Given this list of marker genes FAAP20, TMEM230, GOLGA8H, FAM210B, IPO8, BCDIN3D, TIMMDC1, ZDHHC7, SDHD (NCBI Gene Id 91899), UBL7, NUDT16L1, TRMT5, RAP1A, FES, PRPF6, PGAM1, DPAGT1, CALHM2, TRIM14, ATPAF1, CDK2AP1, DNAJC10, RAC1 (Rac family small GTPase 1), ZWINT, ZNF250 (zinc finger protein 250), TMEM175, ARHGDIB, CAST, ABL1, SORD, TP53TG1, ZFTRAF1, GHDC, ZCCHC13, PLAAT3, MYO1F, GIT2, ADISSP, LIX1L, ZNF362, EIF4A3, FKBP1A, CDKAL1, ITFG1, ACSM3, TCFL5, BTD, SAP30 (NCBI Gene Id 8819), MR1, TMPRSS5, ERCC5, SIPA1, MRPS26 (NCBI Gene Id 81568), ZFYVE19, PCYOX1, DDRGK1, TUBA1C, VAMP8, PYCARD, STMN1, ACBD6, RIDA, STOML1, MIPEP, EHHADH, SNTB1, AHCY, NSMCE4A, RAP1GAP2, KATNB1 (katanin regulatory subunit B1), ATXN10, NAPSB, ARHGAP15, DOCK8, SMARCA2, LDHA, DCXR, SP110, NHERF1, RASGRP4, STK24, RNF214, NUDT6, BRDT, MYCL, ZNF124, CHN2, CTDSP1, ANAPC5, PSME3IP1, TMEM97, DPYD, TCF19, STARD13, DARS2, FBXW4, GDPD5, OAS2, TTC9C, ZNF215, OXNAD1, GIMAP8, AUH, TCIM, GSTK1, EIF3D, VPS35, NUP88, IFI16, MRPS34, MAF, ACLY, SDC3, GPS1, DPH5, WASHC5, CCR1, PARL, CHST12, DDX51, AP3S1, ZNF467, LAPTM5, UVRAG, POLR1E, H2AZ1, HVCN1, OSBPL1A, REEP4, RPIA, ACAA1, ZNF252P-AS1, KIAA2013, SNX2 (NCBI Gene Id 6643), FECH, ENTPD6, GIMAP1, CHIA (NCBI Gene Id 27159, chitinase acidic), CYP4V2, ANKZF1, TPGS2, ALDH3B1, SPATS2L (NCBI Gene Id 26010), TMEM53, PLCL2 (phospholipase C like 2), AIM2, PEBP1, ELMO1, STAC3, ENTPD1-AS1, UBE2F, CEMP1, PHF7, CERS2, AKTIP, CCDC51, USP18, ENSG00000289161, REEP5, NT5DC1, TRIT1, PAIP2B, ESYT1, CPPED1, METTL5, DKC1, ERCC8, NME3, APOL4, FH, HAUS1, CORO1B, HDDC3, VCL, NUP43, TST, DIMT1 (NCBI Gene Id 27292), PHB1, WDR76, EIF4E3, IL26, CNOT7, GLO1, NUDT16L2P, SORT1, KLHDC2, DNMT1, RABGGTA, GALE, SCO2, VPS8, HACD4, CD302, SYNJ2BP, PPP1CC, PARVG, PSTPIP1, here is a description of the gene set: Human Gene Set: GSE11864_CSF1_IFNG_VS_CSF1_IFNG_PAM3CYS_IN_MAC_UP from publication Hu X, Chung AY, Wu I, Foldi J, Chen J, Ji JD, Tateya T, Kang YJ, Han J, Gessler M, Kageyama R, Ivashkiv LB (PMID 18976936) Genes up-regulated in comparison of macrophages cultured with M-CSF and IFNG versus macrophages cultured with M-CSF, IFNG and Pam3Cys (TLR2 agonist). studied in species Homo sapiens Gene expression analysis of freshly isolated CD14+ human monocytes and monocytes cultured in the presence or absence of interferon (IFN) -gamma for 24 h and then stimulated with Pam3Cys, a Toll-like receptor (TLR) 2 ligand, for 6 h. Results provide insight into mechanisms by which IFN-gamma reprograms early macrophage differentiation and subsequent response to TLR ligands.